Given this list of marker genes RBMXL2, PPP1R8, PTAR1, MACC1, CACNA1G, CCDC68, H1-0, SPOCK1, RAP2A, TLE3, FSHB, PIRT, C15orf48, EDN1, ZNF99, MTMR1, FBXO32, GEN1, TRIM39, THUMPD3, ZNF182, ARMC10, STC2, INPP5A, CDK14, ZNF135, SDK2, POM121, ATP4B, AMER2, ELAPOR2, ZNF687, ZFP1, LTBP1 (latent transforming growth factor beta binding protein 1), EBF1, RAD54L, ZNF568, DNAJB5, DCX, CNOT4, ZNF268, IRAK2, POU2F1, ADGRL3, ZEB1, ATXN1L (ataxin 1 like), PAPPA, NRAS, ZNF773, KCNE4, ALCAM, ADIPOR2, GPR26, MCFD2, TNRC6B, SPEN, HIVEP3, TADA1, ZNF440 (zinc finger protein 440), GPC6, SEMA3A, RNF141, ZNF546, RBL2, NYAP2, CPD, CREB5, NPVF, C22orf46P, TTLL12, MAPK14, OSBPL9, ITGAX, DUOX2, ZNF322, ANKRD12, GATA3 (GATA binding protein 3), DTL, WIPF3, PNMA6A, PIK3R1, ZNF426, UBE2B, USP9X, TASOR, KPNA4, FAM47E-STBD1, SOX11, SRP54, GPR161, PRICKLE2, IKZF2, ZFP90, HOMER1, SMDT1, RAPGEF6, CD83, MS4A6A, KCNK10, FAM229B, REEP5 (NCBI Gene Id 94845), ZBTB4, VPS13C, SLC30A5, CERS6, TTPAL, PCSK1, SP100, ZNF589, TIE1, MAPK1IP1L, HMGA2, UBE2J1, XCL1, AGAP1, MTCH2, TFAP2A, NEK2, ZNF700 (zinc finger protein 700), ZNF92 (NCBI Gene Id 7645), ARPP21, CHRNB3, ELOVL3, EDNRA, SET, ZNF37A, EIF5 (NCBI Gene Id 1983), TET3, ATP8A2, STMN1, DERA, USP8, EEIG2, TRIB1, MYOCD, LRRC47, CHD2, LRRC58, SNX30, PROX1, GLI3, PHF21B, CACNA1E, KCNJ18, DUSP6, PRSS35, CHEK1, ZNF138, DDAH1, KCNQ3, TMEM132C, CPM, HS3ST3B1, MBNL1, TP53INP2, EDEM1, NDC1, PTGR3, FECH, CD36, KRBOX4, DACT3 (NCBI Gene Id 147906), TENT5A, VTA1, ZNF317, ZNF25, EDEM3, NDST3, ZNF596, RAB12, LNPK, PERP, PTP4A1, PDGFC, BCOR, AMOT, FAM76A, TMEM87B, GARIN1B, SEL1L, SESTD1, ARHGEF28, CRIM1, here is a description of the gene set: Genes predicted to be targets of miRBase v22 microRNA hsa-miR-629-3p in miRDB v6.0 with MirTarget v4 prediction scores > 80 (high confidence targets). species: Homo sapiens from publication Chen Y, Wang X (PMID 31504780) Human Gene Set: MIR629_3P